The following is a description of a gene set: Background: The live attenuated vaccine Zostavax was developed to prevent varicella zoster virus (VZV) reactivation that causes herpes zoster (shingles) in older humans. However, the impact of vaccination on the cutaneous response to VZV is not known. Methods: We investigated the response to intradermal VZV antigen challenge before and after Zostavax vaccination in participants > 70 years of age by immunohistological and transcriptomic analyses of skin biopsy specimens collected from the challenge site. Results: Vaccination increased the proportion of VZV-specific CD4+ T cells in the blood and promoted the accumulation of both CD4+ and CD8+ T cells in the skin after VZV antigen challenge. However, Zostavax did not alter the proportion of resident memory T cells (CD4+ and CD8+) or CD4+Foxp3+ regulatory T cells in unchallenged skin. After vaccination, there was increased cutaneous T-cell proliferation at the challenge site and also increased recruitment of T cells from the blood, as indicated by an elevated T-cell migratory gene signature. CD8+ T-cell-associated functional genes were also highly induced in the skin after vaccination. Conclusion: Zostavax vaccination does not alter the abundance of cutaneous resident memory T cells but instead increases the recruitment of VZV-specific T cells from the blood and enhances T-cell activation, particularly cells of the CD8+ subset, in the skin after VZV antigen challenge. Genes up-regulated in skin of body VZV challenged post-vaccination vs unchallenged in adults (70-93) (VZV challenge) after exposure to Zostavax, time point 72H. Comment: Table showing the top genes upregulated at 72 hours after varicella zoster virus (VZV) challenge before and after vaccination. species: Homo sapiens Human Gene Set: PATEL_SKIN_OF_BODY_ZOSTAVAX_AGE_70_93YO_VZV_CHALLENGED_POST_VACCINATION_VS_UNCHALLENGED_72HR_TOP_30_DEG_UP from publication Patel NP, Vukmanovic-Stejic M, Suarez-Farinas M, Chambers ES, Sandhu D, Fuentes-Duculan J, Mabbott NA, Rustin MHA, Krueger J, Akbar AN (PMID 30247603), and this is the list of marker genes: GZMB, EOMES, XCL1, IDO1, SELL, CTLA4, FCGR1BP, CLEC4E, FPR1, SERPINA1, LYZ, CLEC12A, TARP, GNLY, TRGC2, TRGV9, FCGR1A, CD8A, CD2, ITGAL, UBD, CXCL9, KLHDC7B, PLAC8, KLRC2, GZMA, CXCL10, CCL5, PRKCQ, GBP5